Given this list of marker genes SCN7A, ATP1B1, TNNI1, KCNH2, CASQ1, KCNE3, DDIT3, KBTBD13 (NCBI Gene Id 651356), TNNC1, PPP1R13L, RYR1 (ryanodine receptor 1), P2RX4, TTN, MIR133A1, CACNA1G (NCBI Gene Id 8913), NPPA, KCNN2, SCN4B, MYL2, RYR3, TNNI2, JSRP1, NOS1, CACNA1C, PRKD1, ATP2A1, FLNA, ATP1A1, BMP10, SRI, HCN4, GJC1, TRPV4, JPH2 (NCBI Gene Id 57362), RYR2, VEGFB, ABCC9, PVALEF, MYH14, FKBP1A, TCAP, KCNE5, SCN5A, PDE4B, SCN3A, CHRNB1, MIR30E, SLC8A3, CACNA2D1, GJA1, SGCD, HSP90AA1, ARG2, PIK3CG, JUP, CASQ2, MYH8, EEF2, KCNE1, SYNM, EHD3, MYBPH, MYH3, CLIC2 (NCBI Gene Id 1193), CACNA1D, ASPH (aspartate beta-hydroxylase), ADRA1A, NKX2-5, DSP, AKAP9 (A-kinase anchoring protein 9), JPH4, JPH1, CSRP3, GPD1L, SUMO1, GJA5, SCN4A, FKBP1B, TRPM4, KCNA5, CACNB2, MYH7B, SCN1B, MTOR, STRIT1, CAV1, MYH6, SLC9A1, PKP2, GSTO1, JPH3, TRDN, RNF207, TNNT1 (troponin T1, slow skeletal type), ZC3H12A, RCSD1, MIR448, NOS1AP, GAA, TNNT3, CHGA (NCBI Gene Id 1113), TPM1, ACTN3, VPS54, MIR328, SCN8A, SCN2B (NCBI Gene Id 6327), KCNJ8, ADRA1B, STC1, ATP2A2, DMPK, KCNJ5, SRSF1, KCNJ2, TNNT2, HRC, HOMER1, FGF12, SLC8A1, SNTA1, LARGE1, ADCY10, ADGRD1, CALM3, MIR1-1 (NCBI Gene Id 406904), CALM2, MIR200C, MAP2K3, STAC3, LMOD3, MYL3, KLHL41, ACTC1, SCN2A, ANK2, C10orf71, SMPX, ADORA1, CAV3, CHRND, BIN1, MYL4, TNNI3, REM1, KCNJ3, PRKACA, DSG2, C12orf57, KCND3, SMAD5, NEDD4L, PGAM2, KCNE2, CHRNA1, DTNA, CCDC78, ATP8A2, RGS2, MYBPC3, TMEM38A, CHUK, SMAD7 (SMAD family member 7), MYLK2, CALM1, CTNNA3, GATA4, DMD, PIK3CA, RANGRF, TNNC2, GSN, ALDOA, KCNE4, MYH7, SCN11A, ARHGEF11, FGF13, GRK2, SELENON, PLN, SCN3B, TNF, STAC2, MAP2K6, CACNA1S, STAC, UCN, SCN1A, NUP155, GSTM2 (glutathione S-transferase mu 2), CAMK2D (calcium/calmodulin dependent protein kinase II delta), PDE4D, TNNI3K, DLG1, TMEM38B, KCNQ1, DSC2, SCN9A, ATP1A2, ACE2, SCN10A, here is a description of the gene set: species: Homo sapiens Human Gene Set: GOBP_STRIATED_MUSCLE_CONTRACTION A process in which force is generated within striated muscle tissue, resulting in the shortening of the muscle. Force generation involves a chemo-mechanical energy conversion step that is carried out by the actin/myosin complex activity, which generates force through ATP hydrolysis. Striated muscle is a type of muscle in which the repeating units (sarcomeres) of the contractile myofibrils are arranged in registry throughout the cell, resulting in transverse or oblique striations observable at the level of the light microscope.